Given this list of marker genes Col17a1, Col18a1, Col22a1, Col9a3, Col6a6, Col9a1, Col5a2, Col15a1, Col5a1, Col27a1, Col6a1, Col4a4, Col4a1, Col9a2, Scara3, Colq, Col4a2, Otol1, Col25a1, Col28a1, Col4a3, Col23a1, Col13a1, Col12a1, Col6a4, Col24a1, Col11a2, Col6a3, Col19a1, Col6a2, Col8a2, Col3a1, Col7a1, Col4a5, Col8a1, Col1a2, Col1a1, Col5a3 (collagen, type V, alpha 3), Col2a1, Col14a1, Col16a1, Col4a6, Marco (macrophage receptor with collagenous structure), Col11a1 (NCBI Gene Id 77655), Col6a5, Col10a1, here is a description of the gene set: Mouse Gene Set: GOMF_EXTRACELLULAR_MATRIX_STRUCTURAL_CONSTITUENT_CONFERRING_TENSILE_STRENGTH species: Mus musculus A constituent of the extracellular matrix that enables the matrix to resist longitudinal stress.